Given this list of marker genes LEFTY1, CHP2 (calcineurin like EF-hand protein 2), ARID4B, PHKG1, HPGD, PIGQ, WASF2, CRCP, DEFB1, RRH, ITIH1, TNFRSF21, SP140, FMO5, GAGE12G, AKAP7, SIX3, RANBP9, NELFA, CD300C (NCBI Gene Id 10871), S100A5, ATP1B2, HTR4, NMB, KIF20B, DPH2, H6PD, DOK2, IKZF1, TJP1, APLP1, TRIM10, LYPD3, SCAMP5, TBXT, SLC6A2, CACNA2D2, FAM131B, FZR1, ADGRL3, EFNA5, EPM2A, CEACAM3, GIP, ACR, SCGN, SLC29A2, SLC17A7, PRF1, FLT1, TUB, CD1C, COX6A2, LCE2B (late cornified envelope 2B), HLA-DOB, HSPBP1, F7, GP9, AMELX, SLC6A6, CYP2E1, LMO1, SLC1A6, COLGALT2 (NCBI Gene Id 23127), CNOT4, PFKFB2, HPS1, ACTL6B, MAGEA9, CDX2, FMO4, SLC30A3, PLIN1, PARD3, STATH, GSTM5, BRME1, MCRS1, UBL3, CDA, DNAH9, QPCT, PLXNA2, DEFB4A, HTR2A, ZP2, P2RY11, KCTD17, ILRUN, PDE4A, HAP1, CHST3, CORT, TBX19, CTAG1B, UBE2D1, RREB1, ECE2, CHIT1, FUT7, BRD4, ARFGAP3, RCAN2, NR0B2, CCNF, LORICRIN, LOX, CSNK2A1, CDK13, PAX6, NTNG1, RUNDC3A, DKK4, SSX4, LIF, GLE1, PPP3CC, MAP4K1, PARP2, VENTX, ATP6V1G2, XDH, NCALD, DMTN, RPH3A, VSIG4, WNT10B, MYOM1, MPP3, SPC25, MLANA, HOXD13 (homeobox D13), CD22 (CD22 molecule), GNG4, SLC6A9, ACKR2, CAMK2B, UCN, TEX261, ZBTB40, CRHR2, ZKSCAN7, ASGR2, DTNB, FCGBP, SAR1A, MSL3, CEBPA, MACIR, TNFRSF13B, MYH2, TDO2, PLAU, TBX1, RBMXL2, NDRG2, STXBP1, HAL, RHBDL1, MET, TM4SF5, FCGR2A, THRA, NDUFA6, MPZL2, SAC3D1, CDH16, CALB2, ZBTB24, MTHFR, PGAM2, CCDC9, ADRA2C (adrenoceptor alpha 2C), COL10A1, TPMT, TUBGCP4, MYOZ3, HPR, PTH2R, LRP3, VCY, ASIC2, GYPB, SCN4A, CRABP1, PDGFRA, POU4F1, GREM1, PRG2 (NCBI Gene Id 87065), RGS9, CBL, SYNGR4, ASGR1, SPN, RASL10A, RECQL5, RECQL4, NAT8, STAT4, NPM3, HTR7, SEMA4D, SLC18A1, ETV3, MSLN, TNNT1, TFAP2B, MPO, CCHCR1, CTSG, CYP2C9, JAKMIP1, NPAS1, CNKSR1, RIBC2, FEV, ENPP4, COL19A1, MAGI1, SULT4A1, SLC13A2, REG1A, KRT32, OVOL2, ATF6B, TBR1, S100A4, HMOX2, CYP11A1, IGHMBP2, GRIK5, TNR, MATN1, KRT6A, PRPH, FUT3, ADD2, GHITM, DIDO1, GAD2, DNALI1, BARX2, FDXR, PRSS16, TRIM15, HSF2, P2RX5, HSD17B1, LY6G6C, MAT1A, PIK3IP1, ARTN, EXD2, REPS2, IKBKG, S1PR4, CSRP3, ADGRL1, ALAS2, SRCAP, PER1, KCND3, SYT5, ESR1, ZNF157, PDK4, VAMP1, IL1RL1, FPR2, DHRS2 (dehydrogenase/reductase 2), VPS11, H3C6, POM121L9P, PAX3, CYP4F12, SLC2A1, EHD1, MPZ, CBLN1, CEP135, SLC7A4, GNG7, PTPRD, MAG, CD3E, CHST1, KIF21B, DPYSL4, CD33, ADAM19, ELAVL2, KRT85 (keratin 85), KIAA0586, FAM13A, AVPR1B, ALDOC, DRD3, KCNN1, SEMA7A, POU6F1, PSG7, ADCYAP1, PTGS1, CACNB1, PRL, PDE4C, ODF1, GPX2, NSG1, EPAS1, ZIC2, ALDOB, RAP2C, BMP1, SEZ6L, PAX4, CEACAM4 (NCBI Gene Id 1089), ADA, TEX28, SRPK3, GPR17, TRIM16, HMHB1, HSD11B2, GATA1, GPA33, AKAP3, CYP2C19, GNMT, CD4, AMMECR1, CNTN6, GPSM3, MLC1, RRP7A, GPRIN2, DVL1, MYEF2, EPOR, ADRA1D, CLCNKA, IVL, PPP3CA, KRT13, HOXD4, DEFA1, IFIT1, ITGA2B, SNX21, FKBP6, GRK3, SPART, INHBC, CCL16, CYP2A7, HTRA2, B3GNT3, ASIC3, PCBP3, L1CAM, NTRK1, PPT2, PNOC, TNP1, ASIP, CASP2, LBP, SMAGP, CD82, OGG1, GFPT2, ACKR1, FANCL, GTF2H3, CD5L, TNFRSF10C, KRT2, VAV2, SCN1B, PLXNA3, HCRT, SLC22A18AS, DAPK2, KCNJ4, TNFRSF10D, SCYL3, TTC22, ANKRD26, KCNA5, MSC, EIF1AY, STARD5, PSD, MLLT1, RCE1, HRG, MAGEA4, ZSCAN12, SLC4A1, KIF1C, GAGE1, SIM2, PZP, PROC, RPS26 (NCBI Gene Id 6231), RAD51D, ITGA10, NECTIN1, UNC119B, TGOLN2, PTPRU, CELA2B, PIGL, BMP10, EDA, RAPGEF5, MEF2C, SNAP25, MYBPC2, INTS9 (integrator complex subunit 9), CYP2D6, LRCH4, SLC7A11, SOX10, MYCL, DUS4L, AAK1, ZC3H14, CAPN3, PRRC1, CHRNB1, TRPM2, GALR3, ARID1A, PHF20, MPP2, SERPINA4, EMID1, TOP3B, GRPR, SH3BP1, HOXD10, NRG2, ZNF143, SLC22A6, CHRNE, CHRNB4, ATOSB, CCL7, CYP2F1, SHBG (sex hormone binding globulin), MAGEC1, PAX7, CSTF2, APOM (apolipoprotein M), ABCA1, KRT86, GRK1, GRIK2, ENTPD2, SZT2, TLE3, CREBZF, VASH1, ST6GALNAC4, OPRL1, ADAMTSL2, GTSE1, EXOSC2, PLCB2, PPP6R2 (NCBI Gene Id 9701), ABCC8, FAT2, CCL13, IVD (NCBI Gene Id 3712), SLC6A11, CYP27B1, CCKAR, ATP4A, NRXN1, YPEL1, MMP2, PI3, TACC2 (transforming acidic coiled-coil containing protein 2), SLIT3, KCNAB1, COL1A1, H2BC17, IL3, LRIT1, RAC2, ABO, HRK, CYP2A6, DLG4, AQP5, NEURL1, LGR5, TMSB4Y (NCBI Gene Id 9087), PRSS3, DSG1, HOXC11, ACACA, APC2, AGXT, RIMS2, ELK3, PRELID3A, DCBLD2, GPR3, TCL1A, ZBED4, KCNQ3, CMA1, EFNA3, FCN2, NEMF, SLC6A7, SLC17A3, KRT4, MAPK13, ISG20L2, ALOX12, REG1B, SPINK2, DMBT1, GGA2, CD8A, ALPG, SIT1, CD86, NTSR2 (NCBI Gene Id 23620), CIAPIN1 (cytokine induced apoptosis inhibitor 1), S1PR2, SFTPC, BNIP1, ALPI, SCN2B, SLC5A2, CD72, BUD23, PIAS1, ADAM20, CARD10, AANAT, ZBTB7A, CST7 (cystatin F, NCBI Gene Id 8530), KRT33B, GJB5, CDK5R2, CSH2, PHYHIP (phytanoyl-CoA 2-hydroxylase interacting protein), SPRR2C, GSTT1, LTC4S, SIX6, ALOX15, ING1, LILRA4, MYOG, TAGLN3 (NCBI Gene Id 29114), ABCB9, CHP1, MID1, PDCD1, N4BP2L1, here is a description of the gene set: Human Gene Set: MODULE_41 studied in species Homo sapiens Genes in the cancer module 41.